Given this list of marker genes Dcun1d1, Lrrc58, Exoc6, Gprasp1, Rps20, Frat1, Fam168a, Jcad, Rapgef6, Snx27, Mmp16, Camk2d, Golim4, Synpo2l, Slc16a10, Ube2k, Gabra3, Meioc, Zfp1004, Fis1, Zfp781b, Fndc3a, Apc, Ptprm, Mapk8, Pitpnb, Ppp1r9a, Lrrc32, Asph, Abr, Atmin, Igf2r, Stc1, Kidins220, Adrb2, Usp32, Prdm8, Mbnl2, Ip6k2, Hmgn1, Ptbp1, Ranbp9, Obox3, Mylk, Pak3, Dkk1, Col15a1, Calu, Erp29, Cdk8 (cyclin dependent kinase 8), Pdha1, Birc6, Syncrip, Dnah5 (NCBI Gene Id 170953), Zfp345, Zfp445, Setbp1, Ivns1abp, Fzd3, Poc1b, Ptchd4, Slain2, Myt1l, Tmem117, Cenpc1, Eef2k, Zfp28, Ubxn8, Sntg1 (syntrophin, gamma 1), Zfp120, Por, Fam107b, Pnn, Psmb11, Cnot7, Pkn2, Tmed5, Pcf11, Neto2, here is a description of the gene set: studied in species Mus musculus Genes predicted to be targets of miRBase v22 microRNA mmu_miR_6401 in miRDB v6.0 with MirTarget v4 prediction scores > 80 (high confidence targets). from publication Chen Y, Wang X (PMID 31504780) Mouse Gene Set: MIR_6401